Given this list of marker genes RUNX3, ITGA4, CBFB, RORC, ITGAL, SPP1, here is a description of the gene set: RUNX3 Regulates Immune Response and Cell Migration species: Homo sapiens Human Gene Set: REACTOME_RUNX3_REGULATES_IMMUNE_RESPONSE_AND_CELL_MIGRATION